The following is a description of a gene set: from publication Aizarani N, Saviano A, Sagar, Mailly L, Durand S, Herman JS, Pessaux P, Baumert TF, Grün D (PMID 31292543) studied in species Homo sapiens Human Gene Set: AIZARANI_LIVER_C11_HEPATOCYTES_1, and this is the list of marker genes: APOE, DECR1, APOA5, IGFBP2, AZGP1, BHMT2 (NCBI Gene Id 54779), GADD45G (growth arrest and DNA damage inducible gamma), UGT2B10, SULT2A1, FGB, GBA3, AGXT, IL1RAP, HAAO, CES1, PPP1R1A, IDH1, PAH, PTMS, G6PC1, SLC2A2, C8A, ITIH1, APOA2 (apolipoprotein A2), CMBL, PROX1, CFL2, CP, EPHX1, CFHR1, RGN, SORD, F2 (NCBI Gene Id 14061), CYP2C9, CYP4F2, F9, ARG1, PLG, SPP2, PHYH, HPGD, APOF, KNG1, GLYAT, ORM1, MT1G, GADD45A, ADH1B, APOC4-APOC2, ALDH2, DCXR, MAT1A, APOM, NADK2, EHHADH, LINC00844, SLC10A1, MT1M, A1BG, ASGR1, SERPINA1, GOT1, GYS2, MMUT, PSAT1, LINC01554, C4BPA, ACAT1, HAO2, ADH1A, HULC, UPB1, ZFAND5, FTCD, ADI1 (NCBI Gene Id 55256), C2, HAO1, PIPOX, PROZ (protein Z, vitamin K dependent plasma glycoprotein), C9, APOC1, GSTA2, TF, LRG1, CYP8B1, ORM2, SLC39A14, CFHR4, CLU, MT1X, F5, HAMP (NCBI Gene Id 57817), CALD1, SERPINA3, A1CF, KLKB1, CYP2C19, TTR, ANG, CYP2C8, RCL1, AKR1C4, ALB, ASS1, GRHPR, C8B, HLF (NCBI Gene Id 3131), ALDH1A1, FGA, PTGR1, ACADM, AADAC, SERPIND1, CFH, MTHFS, OAT, DPYS, GC (GC vitamin D binding protein), CYP27A1, SLC22A1, FBP1, PROC, MSMO1, CYP1A2, SHMT1, LECT2, AOX1, RETREG1, C11orf54, GNMT, SERPINF2, ANGPTL3, FGL1, COBLL1, RBP4, UQCRQ, MST1, CFHR3, C1R, CYB5A, C5, BAAT (bile acid-CoA:amino acid N-acyltransferase), ALDH1L1, ALDH8A1, MT2A, PCK2, TMBIM6, ASGR2, ALDH7A1, CYP3A5, SMIM14, FABP1, SLC27A5, CYP2A13, UGP2, FN1, ABCA1, HSD17B6, ACADSB, ELL2, ADH6, MT1E, FMO5 (NCBI Gene Id 2330), GATM, SOD1, HSD11B1, TMEM176A, MYO1B, PRDX3, CBR1, CAT, GSTA1, SERPING1, PGRMC1, SLC27A2, CYP3A4, ITIH2, CYP4F3, SERPINE1, C6, ECHS1 (enoyl-CoA hydratase, short chain 1), HPD, SERPINA11, C3, AR, RARRES2, ITIH3, ACSM5, MBL2, SDS, C4BPB, TMT1A, PBLD, APOC4, FMO3, HSD17B13, ERRFI1, LIPC, HMGCS2, PEBP1, INSIG1, ENPP1, CFI, SDC2, CES2, PCK1, ATF5 (activating transcription factor 5), PRG4 (NCBI Gene Id 787), CPN2, HP, MGST1, SLC38A4, APOC3, PCBD1, LINC00261, ABAT, SCD, NNMT, APOH, PON3, MAOB, MTTP, SELENBP1, TAT, AMBP, GGH, APOA1, SERPINF1 (NCBI Gene Id 5176), AGT, HRG (histidine rich glycoprotein), GPT2, ACSL1, CDO1, CPB2, C1S, CFB, IGF2, BCHE, RHOB, GHR, AFM, CYP2E1, SDC4, APCS, ACSM2A, ACAA2, SLC7A2, HPR, HPN, MT1F, ADH4, SCP2 (sterol carrier protein 2), BNIP3, LEAP2, CPS1, F12, PRDX6, SLC13A5, ALDH6A1, UGT2B15 (UDP glucuronosyltransferase family 2 member B15), AKR1D1, PON1, GLUD1, ALDOB, GLYATL1, KLF15, UGT2B4, CXCL1, RIDA, ECHDC2, PTP4A1, PPARGC1A, AQP9 (aquaporin 9), HAL (histidine ammonia-lyase), IGFBP1, PLIN2, TMEM176B, PDK4, UGT2B7, TLCD4, HGD, BHMT, CYP2B6, MTHFD1, HPX, CYP4A11, ATP5PF, SERPINC1, APOB, FGG (fibrinogen gamma chain), VNN1, AHSG, VTN, TDO2, DHTKD1, ALAS1, MLXIPL, AKR1C1